Given this list of marker genes MTRF1L, MRPS18B, MRPL30, MRPL12, MRPL1, MRPL52, MRPL57, MRRF, MT-TV, MRPL55 (mitochondrial ribosomal protein L55), MTRF1, MT-ATP6, OXA1L, MRPL35, KGD4, MT-ND4L, MRPL9, MT-CO3, MRPL58, MRPL4, MRPL36, MRPL41, MRPL20, MRPL39, MRPL15, MRPL11, MRPL2, MRPS15, MRPL40, MRPL16, MRPS18A, MRPL42, MRPL49, MT-ND2, MRPS11, MRPL43, MRPL47, MRPS2, MRPL24, MRPL27, MRPL23, MRPL44, MRPL10, MRPS28, MT-CO2, MRPL33, MT-RNR2, MRPS5, MRPS10, MRPS27, MRPS16, MRPS33, MT-CYB, MRPS21, MRPS35, MRPS12, MRPS34, MRPS23, MRPS6, GFM2, MT-RNR1, ERAL1, MRPS22, MRPL51, MRPL48, MRPL37, MRPL14, MRPS14, MRPS7, MT-ND6, MRPL19, PTCD3, MRPS31, MRPL54, MRPS17, MRPS9, MRPL21, MRPS25 (mitochondrial ribosomal protein S25), MRPL3, MRPL50, MRPS30, MRPL17, MRPL45, MRPL13, MRPS24, MT-CO1, MRPL38, MT-ATP8, MT-ND1, AURKAIP1, MRPS18C (mitochondrial ribosomal protein S18C), MT-ND4, DAP3, MRPL53, MT-ND3, MRPL18, MRPL28, MRPL46, CHCHD1, GADD45GIP1, MRPL32, MRPL34, MT-ND5, MRPL22, MRPS26, here is a description of the gene set: Reactome Pathway: Mitochondrial translation termination part of: Mitochondrial translation Translation is terminated for 11 of the 13 mitochondrially encoded proteins when MTRF1L (MTRF1a) recognizes a UAA or UAG termination codon in the mRNA at the A site of the ribosome. Translation of the MT-CO1 and MT-ND6 proteins is terminated at an AGG codon and an AGA codon, respectively. These two noncanonical stop codons are recognized by MTRF1. GTP is hydrolyzed, and the aminoacyl bond between the translated polypeptide and the final tRNA at the P site is hydrolyzed by the 39S ribosomal subunit, releasing the translated polypeptide. MRRF (RRF) and GFM2:GTP (EF-G2mt:GTP) then act to release the remaining tRNA and mRNA from the ribosome and dissociate the 55S ribosome into 28S and 39S subunits. studied in species Homo sapiens